The following is a description of a gene set: Any process that modulates the frequency, rate or extent of a process involved in the formation, arrangement of constituent parts, or disassembly of an organelle. Mouse Gene Set: GOBP_REGULATION_OF_ORGANELLE_ORGANIZATION species: Mus musculus, and this is the list of marker genes: Coro2b, Hrg, Capg, Clec2i, Ik, Atg5, Fgfr1, Bmp7, Mief1, Apc, Pikfyve, Spag5, Ssh1, Pfn5, Twf2 (twinfilin actin binding protein 2), Myh9 (myosin, heavy polypeptide 9, non-muscle), Ncaph2, Arhgap17, Arhgap18, Cotl1, Shroom2, Abitram, Ino80c, Sgk1, Vps35, Kat2a, Macroh2a1, Nanos2, Mapk15, Sptbn2, Grik5, Syde1, Laptm4b, Bub1, Chmp5, Stn1, Arhgap35, Chmp1b, Sec16a, Csf2, Pnkp (NCBI Gene Id 76351), Smarcc2, Snca, Bcas3, Daam2, Gm14137, Znrf2, Cfl2, Tom1l1, Phf23, Nckap1, Actg1, Eif4g3, Fam162a, C2cd5, Poc1b, Carmil3, Cdk2ap2, Rhot1, Tac1, Ap1ar, Nes, Tmem14a, Cenpj, Carlr, Bicd1, Cct5, Bmyc, Lmod2, Cltc, Anapc2, Wmp, Adck1, Bok, Stmn3, Tbc1d30, Nrxn1 (neurexin I), Yy1, Plekhg2, Lima1, 2610042L04Rik, Cdca2, Fgfr2, Capza3, Slain2 (SLAIN motif family, member 2), Dpf1, Snx7, Dapk3, Washc4, Syt4, Arhgef9, Anxa2, Nme7, Atp13a2, Cdk1, Siglec15, Pml, Klf4, Cdc42ep2, Cdk2, Mad2l1bp (MAD2L1 binding protein), Usp10, Gap43, Fgfr3, Birc5, Tacr1, Nedd9, Gpr3, Ppif, Mcu, Riok2, Rhog, Ccl21a, Katnbl1 (NCBI Gene Id 98995), Fsd1, Arfip2, Ercc4, Cdk10, Dynlt1a, Trim54, Anapc15-ps, Ift46 (intraflagellar transport 46), Grid2, Csf3 (NCBI Gene Id 12985), Tnks, Rhobtb2, Sema5a, Cdh5, Nek7 (NIMA (never in mitosis gene a)-related expressed kinase 7), Ttbk2, Slain1, Ngef, Sec22b, Ccdc15, Smarca4, Arap3, Ankrd66, Kiss1r, Nsmce2, Actn2, Znrf1, Ddhd1 (DDHD domain containing 1), Parp3, Hdac8, Ube2b, Cdc42ep5, Tfpt, Slx1b, Cracd (capping protein inhibiting regulator of actin), Lrrk2, Traf3ip1, Sipa1l1, Limch1, Adamts16, Atl3, Cav2, Usp44, Pif1, Hnrnpa2b1, Myo1f, Coro1a, Mfn2, Mapk9, F2rl1, Arpc5, Tgfb2, Cyfip2, Msn, Edn3, Anapc1, Inpp5j, Ccl24, Dynlt1f, Hnrnpd, Hdac2, Arhgef26, Potefam3a, Bmp10, Mff, Tmsb15b2, Phldb1, Nek2, Dnm1l, Cdc27, Pafah1b1, Insr, Gpm6b, Asap3, Doc2g, Washc2, Ccl21d, Dync1h1, Tmod1, Stox1, Sar1a, Stra8, Lmod3, Cbln1, Togaram2, Slc35f6, Hoxa13 (homeobox A13), Vps11, Cep135, Nrp1, Vil1 (villin 1), Ptbp1, Actb, Ehmt2, Cenpv, Carmil1, Map2k7, Spc25, Syt5, Nvl, Gclc, Cdc16, Lman1, Esam, Pfn1, Arpc3, Bmp4, Cdc42ep4, Sh2b1, Rps3, Cul3, Spdl1 (NCBI Gene Id 76404), Anapc5, Tbcd, Cdk5rap2, Lif, Dbnl, Mapre3, Dlg1, Svil, Knl1, Upf1, Smad4, Rnf186, Mcrs1, Nav3, Plcb1, Baiap2, Cplx4, Vangl2, Prkd1, Rph3a, Kif5b, Gpr65 (G-protein coupled receptor 65), Sirt6, Ptges3, Ppm1e, Ndc80, Cgnl1, Fam107a, D7Ertd443e, Ift140, Prkaa2, Rps6ka2, Psrc1, Ino80e, Ckap2, Id1, Mef2c, Lmna, Cplx3, Rhoa, Ttk, Dcn, Iqschfp (NCBI Gene Id 100505386), Smpd3, Tmod3, Cep70, Mre11a, Cd28, Pdcd5, Gba2, Trim36, Kctd17, Cnot1, Stx18, Saxo1, Mid1, Gm28729, Rab3gap2, Sh3bp1, Pde2a, Dkc1, Hras, Trpm2, Tgfb1, Zfp13, Prelid1, Cib1, Mtor, Anapc7, Stat2, Psmg2, Irgm2, Gmfb, Rph3al, Ccl21e (C-C motif chemokine ligand 21E), Smc5, Sdc4, Tgfbr1, Prickle1, Cct3, Rock2, Tmem39a, Ncapd3, Slc25a31, Ptk2b, Fis1, Htt, Mark2, Odf2l, Tmsb4x, Ccp110 (centriolar coiled coil protein 110), Armh3, Gja1, Shank1, Smarcc1, Capza1, Camsap3, Syt8, Fchsd2, Katnb1, Gsn, Arap1, Bcl7b, Kank2, Smad3, Smarca5, Cdc23, Cdc20, Magel2, Bcl2l1, Rab11fip3, Cdh2, Map3k1, Cdk5r2, Arpin, Tbc1d7, Cdk5r1, Clasp2 (CLIP associating protein 2), Prkn, Dyrk1a, Doc2b, Nat10, Tesk1, Rgs4, Syt11, Kank3, Cript, Trim37, Nckap1l, Entr1 (endosome associated trafficking regulator 1), Tchp, Baiap2l2, Pot1a, Kat2b, Nck2, Cdkn1b, Bad, Cep97, Prrt2, Jam3, Map2, Smarcd2, Taok1, Cct6a (NCBI Gene Id 12466), Bid, Rad1, Rabep2, Terf2ip, Ift88, Map1a, Spef1, Noto, Ncapg2 (NCBI Gene Id 76044), Bmerb1 (bMERB domain containing 1), Ier3, Syt13, Slc2a4, Arhgap44, Bin1, Tmod4, Epha5, Ino80, Specc1l, Arhgef10l, Wasf2, Prickle2, Zmynd8, Ssbp1, Egf, Surf4, Cplx1, Stmnd1, Tmem135, Xrcc4, Capzb, Terf2 (NCBI Gene Id 21750), Syt7, Pip4k2b, Pip4k2c, Cdkl1 (cyclin dependent kinase like 1), Rad21, Map9, Pink1, Nup62, Ubap2l, Anapc15, Hsf1, Rnd1, Pkd1, Preb, Nexn, Cplane2, Crk, Espn, Gen1, Mycbp2, Tsg101, Tmem67, Kif24, Hip1r, Celsr1, Atr, Wapl, Rac2, Tsc1, Lrfn4 (NCBI Gene Id 225875), Npm2, Snx30, Igf1r, Naf1, Dynlt2b, Arpc5l, Capza2, Igf2, Lig4, Cfl1, Dynll1, Erc1, Rae1, Rhpn2, Terf1 (NCBI Gene Id 21749), Sh3pxd2b, Wnt4, Slc25a5, Arhgef16, Syne2, Apoa1, Nck1, Wasf3, Limk1, Mos, Cit, Bcl7a, Shcbp1l, Ankrd27 (NCBI Gene Id 352948), Mki67, Grhl3, Mad2l1, Cd2ap, Mcph1, Csf1r, Ncapg, Fermt2, Abl1, Atrx, Ep300 (NCBI Gene Id 328572), Marchf5, Wdpcp, Fnip1, Vamp1, Rad51ap1, Wnt11, Dstn, Cnot6l, Erc2, Ccnf, Akap13, Cntrob, G3bp1, Ccl21b, Rbm14 (RNA binding motif protein 14), Limk2, Higd1a, Eml3, Odf2, Sirt7, Cep120, Rac1 (Rac family small GTPase 1), Taok2, Grb2, Dpf3, Ezr, Atat1, Ccnb1, Ppfia1, Ccnb1-ps, Oma1, Tex14 (NCBI Gene Id 97747), Tcp1, Anxa1, Whamm, Slx4, Avil, S1pr1, Pla2g6, Apc2, Abi3, Arfip1, Snx18, Bik, Nbn, Arpc2, Marchf7, Stmn1, Zeb2, Abi2, Moap1, Obsl1, Epgn, Pak3, Mtss1, Lrp5, Map6 (microtubule-associated protein 6), Bag4, Chmp3, Myoc, Lrrc4b, Alox15, Cyld, Camsap2, Cnot6, Acaa2, Drg1, Bak1, Pfdn2, Syt2, Terc, Mcidas, Rimbp2, Fen1, Fkbp4, Rnh1, Xrcc5, Il1b, Atg2a, Shank3, Clstn3, Fhod3, Usp6nl, Rab1b, Neb, Khdc3, Il1rap, Yme1l1, Cct2, Efna5, Caprin1, Irgm1, Huwe1, Itgb1bp1, L3mbtl1, Add2 (NCBI Gene Id 72970), Arhgef5, Tpr, Stx5a, Tmem102, Ereg, Myo3b, Cav1 (NCBI Gene Id 12389), Stil, Fbxo5, Kif18a, Hgf, Pjvk, Dazl, Stmn2, Cep295nl, Doc2a, Rmi2, Mgarp, Clip1, Snx4, Mtm1, Tmed9, Bmf, Mtch2, Lmod1, Arhgef7, Slf2, Wee2, Ccdc88c, Siva1, Slc4a2, Mapk3 (mitogen-activated protein kinase 3), Spast, F11r, Epha3, Ppp3cb (protein phosphatase 3, catalytic subunit, beta isoform), Dcdc2a, Hrk, Tenm1, Rab3ip, Arhgef2, Xrcc1, Trappc12 (trafficking protein particle complex 12), Rictor, Bub1b, Ino80d, Rnf4, Plekhh2 (NCBI Gene Id 213556), Spata4, Zwilch, Naa20, Ube2u, Arf4, Sfpq, Rab33b, Mapk8, Ssh2, Spice1, Baz1b, Atxn7, Tppp, Lnpk, Smarcb1, Nphs1, Tbc1d12, Nek6, Gch1, Ppp1r9a, Rb1, Frmd7, Pdlim4, Zwint, Mfn1, Slc39a12, Dixdc1, Ptprs, Parl, Klhl22 (NCBI Gene Id 72509), Dpf2, Rab3gap1, Arap2, Bst2, Golph3 (golgi phosphoprotein 3), Sorbs3, Rbsn, Pick1, Pfn2, Bora, Lrsam1, Smarcd1, Hspa1a, Ska1, Lrrtm1, Lcp1, Ruvbl2, Ccdc8, Chmp2a, Tal1, Ube2c, Fez2, Rdx, Ccl27a, Pde3a, Atp5if1, Wdr44, Diaph3, Cnot2, Zfy2, Rnf5, H3f3a, Map3k4, Pkib, Arid2, Odam, Trpv4, Add3, Prune1 (prune exopolyphosphatase), Pdcd5-ps, Dync2li1, Pla2g4a (NCBI Gene Id 226493), Src, Actr5, Ckap5, Dnai3, Cct7, Cd47, Mir129-2, Fbxo4, Pfn3, Prmt6, Gpr143, Rgcc, Phip, Spire1, Cdkl5, Bbs4, Vps4b, Sdc1 (NCBI Gene Id 20969), Smarcd3, Mid1ip1, Abi3bp, Ins2, Btc, Anapc11, Pip4k2a, Ywhah, Trim27, Nox4, G3bp2, Ift20, Cep192, Kat5, Chmp4b, Arl6ip1 (NCBI Gene Id 97394), Zfp207, Actl6b, Tubg1, Pebp1, Potefam3b, Hif1a, Tmod2, Smg1, Trim9, Kntc1, Osm, Tnks2, Smcr8, Hdgfl3, Pparg, Kif9, Phldb2, Pinx1, Chchd10, Mphosph9, Haspin, Tapt1, Fbxo43, Prex1, Cep295, Rims2, Actl6a, Flii, Fzd9, Zw10, Sphk1, Ctnna2, Slc30a1, Tom1, Bcl2l2, Washc1, Pbrm1, Lrp1, Meiosin, Ska3, Scfd1, Grn, Mark4, Lrfn1, Rab11a, Eml2, Tjp1, Synpo2 (NCBI Gene Id 99735), Pak1, Lpar1, Ralb, Fmn1, Gmfg, Mmp9, Cenatac, Plxnb1, Cyfip1, Rp1, Rhod, Mapre2, Map1b, Gnai1, Pam, 4930550C14Rik, Ccl21f, Map2k1, Cct8, Arhgap6, Kifc1, Prkcd, Kif21a, Tnf, Opa1 (NCBI Gene Id 74143), Icam1, Mtnap1, Chmp1b2, Bcl2l11, Mcoln1, Syt1, Arhgef15, Bax (BCL2-associated X protein), Flna, Nfe2l1, Plek, Pycard, Prkce, Bbc3, Arrb2, Dmrt1, Cacna1b, Bub3, Chfr, Aurka, Smim22, Pdgfrb (NCBI Gene Id 18596), Evl, Hnrnpc, Swap70, Nbdy, Setmar, Scin, Arhgef18, Eml4, Plk1, Arhgef19, Map2k2, Wdr45, Numa1, Rasa1, Arl2, Xirp2, Arfgef1, Ncaph, Fchsd1, Il5, Htr1a, Ppm1f, Actr8, Ccn2, Tlr2, Evi5l, Fuz, Pmaip1, Avp, Bst1, Anapc4, Cdc42ep1, Togaram1, Rtel1, Prox1, Recql4, Cul9, Mpv17l, Myo1c, Stam, Pla2g5, Kank1, Psmd10, Mapt, Slc25a4, Npm1, Ooep, Nfrkb, Parp1, Sgo2a, Myo3a, Fgf8, Pak2, Sptan1, Calr, Slit2, Mlst8, Flcn, Add1, Exosc10, Sdccag8, Mief2, Trip13, Ppp1r10, Fez1, Pisd, Mkks, Syt9, Osbp, Smc2, Sirt2, Vat1, Ctnnb1, Serpinf2, Naa10, Myo19, Chmp6, Nlgn1, Epha1, Prdm9, Nabp2, Wipi1, Tmem106b, Pxn, Ppargc1a, Prkcq, Rnd2, Myc, Mapre1, Tmsb15l, Gpx1, Rubcn, Fscn1, Naa80, Hormad1, Pqbp1, Pik3r1, Synj1, Lrrtm2, Rnd3, Camsap1, Rhoc, Fxn, Ercc1, Ehd3, Bicd2, Kdr, Igf1, Capn6, Rap1gds1, Iqgap2, Crocc, Wnt5a, Cav3, Cdc42, Mdm1, Atg3, Capn10, Dhodh, P2rx7, Gda, Nptxr, Fas, Arf1, Actr3, Tent4b, Inpp5k, Eps8, Wrap73, Micu1, Sar1b, Ubqln4, Rims1, Vill, Pan3, Arhgap33os, Smarca2, Dynlt1c, Abcg1, Smarce1, Dctn1, Incenp, Pot1b, Hsph1, Slamf1, Xrcc3, Bbof1, Ect2, Cenpe, Dcp2, Chmp4c, Luzp1, Tgfa, Mns1 (NCBI Gene Id 17427), Hmbox1, Nuf2, Synpo2l, Arhgap28 (NCBI Gene Id 268970), Rad50, Inf2, Hap1, Mllt11, Itgb3, Plscr3, Ankrd53, Cul7, Arhgap40, Lcmt1, Fgr, Pcid2, Ephb2, Dzip1, Rhpn1, Cdk11b, Wnt3a, Cln3, Capn1, Tpx2, Tacc3, Myadm, C9orf72, Tecpr1, Ncapd2, Rcc1, Plaur, Nusap1, Npr2, Spef1l, Ska2, Plxna3, Ddhd2, Cdc42ep3, Map1s, Aurkb, Nubp1 (NCBI Gene Id 26425), Eln, Hnrnpu, Capza1b, Stmn4, Mak, Arf6, Fes, Cplx2, S100a10, Ddx11, Fyco1, Ruvbl1, Agrn, Brd7, Nupr1, Pdcd6ip, Psma8, Ghitm, Tnfsf10, Hecw2, Gas2l1, Slc30a9, Fbxw5, Sdcbp, Ppp1r35, Fgf13, Stxbp1, Dhx36, Mul1 (mitochondrial ubiquitin ligase activator of NFKB 1), Trex1, Cct4, Akt1, Slf1, Fshr, Mir539, Tbc1d4, Parn, Odad3, Coro1b, Cdca8, Efnb1, Bcl7c, H3f3b, Akap9, Dlc1, Senp6, Diaph1, Gdi2, Prpf4b, Zdhhc6, Twf1, Met, Smg6, Dusp1, Inppl1, Cyrib, Chmp7, Plk2, Baiap2l1, Chmp1a, Ilk, Ankrd23, Ralbp1, Zmynd10, Vasp, Cdc6, Trp53, Ccsap, Ino80b, Yap1, Was, Pan2 (NCBI Gene Id 71734), Tinf2, Dbn1 (NCBI Gene Id 56320), Wdr35, Bnip3, Uchl5, Ptger4, Camk2b, Dmtn, Pdxp, Git1, Mtbp, Syt3, Prap1, Calcoco2, Hspa1b, Sirt1, Clasp1, Phf10, Ten1, Lats1, Cttn, Pgam5, Stau2 (staufen double-stranded RNA binding protein 2), Snx9 (sorting nexin 9), Ccl26, Esr1 (NCBI Gene Id 13982), Dnm2, Cep76, Fhod1, Mecp2, Cyria, Mavs, Alms1, Ssh3, Edn1, Nme6, Acd, Synpo, Patl2, Brk1, Fer, Wdr1, Drd3, Arhgef10, Ylpm1, Pde4dip, Ctc1, Ccl11, Hdac6, Map6d1, Wdhd1, Sptb, Tbc1d25 (TBC1 domain family, member 25), Chek2, Rhobtb1, Gnl3, Pecam1, Ripor2, Hcls1, Rab3a, Tom1l2, Atmin (NCBI Gene Id 234776), Gsk3a, Tmeff2, Syne1, Ins1, Sh3glb1, Mtpn, Gnl3l, Chmp2b (charged multivesicular body protein 2B), Gsk3b, Braf, Mad1l1, Rala, Spta1, Gas2l2, Igtp, Atm (NCBI Gene Id 77416), Plk4, Pik3ca, Spc24, Elapor1, Rapgef3, Pik3r2, Smc4, Tmem33, Chek1, Wasf1, Sass6, Septin9 (septin 9), Tfrc, Fzr1, Fzd10, Mtmr3, Ulk1, Mapk1, 4930544G11Rik, Prkaa1, Arid1a (NCBI Gene Id 93760), Cx3cl1, Clip3, Clec16a (NCBI Gene Id 74374), Piwil2, Rock1, Nf2, Caskin1, Axin2, Atg12, Msx2, Styxl1, Rhof, Rac3, Intu, Mylk3, Mapkapk5, Becn1, Dynlt1b, Hck, Endog, Washc5, Carmil2, Gper1, Trim32, Tacstd2, Pld6, Ubqln2, Kirrel1, Sptbn1, Gpsm2, Ccdc88a, Smg5, Tpm1, Wdr47, Kank4, Wrap53, Nol3, Tbc1d14, Il1a, Hax1, Pdgfb, Msx1, Dync1li1, Tgfb3, Washc3, Ank1, Tubb4a, Ptprd, Ttc8, Triap1, Adrb2